The following is a description of a gene set: Genes down-regulated in skin from 129S1 mice after injection of: control versus Trypanosoma cruzi (strain Y). from publication Chessler AD, Unnikrishnan M, Bei AK, Daily JP, Burleigh BA (PMID 19201883) species: Homo sapiens Human Gene Set: GSE13522_CTRL_VS_T_CRUZI_Y_STRAIN_INF_SKIN_129_MOUSE_DN To investigate the early host response triggered by three different strains of Trypanosoma cruzi at a local infection site, changes in host gene expression were monitored in a murine intradermal infection model using Affymetrix oligonucleotide arrays. Robust induction of IFN-stimulated genes (ISGs) was observed in excised skin 24 hours post-infection where the level of ISG induction was parasite strain-dependent with the least virulent strain triggering a muted IFN response. Infection of mice immunodepleted of IFNγ-producing cells or infection of IFNγ-deficient mice had minimal impact on the IFN response generated in T. cruzi infected mice. In contrast, infection of mice lacking the type I IFN receptor demonstrated that type I IFNs are largely responsible for the IFN response generated at the site of infection. These data highlight type I IFNs as important components of the innate immune response to T. cruzi the site of inoculation and their role in shaping the early transcriptional response to this pathogen. We used microarrays to detail the local host transcriptional response to intradermal T. cruzi infection in WT mice and mice depleted of NK cells, or deficient in IFN-gamma or type I IFN responses. Additionally we compared the local host-transcriptional response generated to infection with 3 different strains of Trypanosoma cruzi (Y, Brazil, and G)., and this is the list of marker genes: SHC4, POPDC2, ADGRD1, ADORA2A, LAPTM4B, RHBDL2, PIR, TAB2, LPAR4, SMOX, ARMCX6, PRSS46P, ABCA2, PHLPP1, RSRP1, TCF7L1, MYORG, NOL3, GPR143, HOMER2, FAM53B, TCF25, SAV1, CDC42SE2, TAS1R1, ENO3 (enolase 3), MAT2B, COL4A4, SNX33, DNAH7, CCDC160, CAVIN1, RBPMS2, PRPH2, SPHK2, ZNF585A, PATL2, RELB, SFXN3, COL19A1, CUBN, MRTFB, LAD1, TMEM222, STAG1, PTDSS1, PRDM2, PRKX, SELENOM, PFN2, RPL5, MTMR3, BRINP1, ZBED3, PTPN5, ZNF354A, STON1, FHL1, ADAMTS6, CAMK2N1, OCRL, MFSD2B, MEX3B, PHF23, F7, CTDSP2, CCDC162P, C8orf74, OLIG1, STAM2, RRAGD, B3GNT5, GMCL1, RXRA, NECAP2, ZNF521, MAGED1, MTMR11, PRKAG2, KDM8, BARHL2, CAST, NAP1L3, CYP3A7, BIN1, KCNJ9, C5orf52, SOX30, FCHSD2, ANKRD2, NLRP4, KCNA5, EDEM2, STAT5B, CCDC92, CLVS1, SPAG4, AHCYL2, FBXO45, ARHGEF11, ID3, CRKL, CD5, PLCL1, BRF2, SNX18, SLC37A2, ASCL1, S100G, CCDC116, FAM98C, SUSD2, ID4, PCMTD1, PFAS, GPRASP2, CYBRD1, NHLH2, ESYT2, BIRC2, TOM1L2, ATP1B3 (NCBI Gene Id 483), ARHGEF16, G6PC2, PROX1, FNDC9, RASSF9, TNP1, LYSMD2, ATP10D, TPPP3, RPRML, KIF5C, SWAP70, RECK, PDGFA, ZFP64, CERS4, RIPPLY3, SLC12A6, NUDCD3, PELI2, SRRM1, SETX, FLOT1, CD81, PCTP, SLC25A31, NME8, FBXO31 (NCBI Gene Id 84204), CATSPERD, TRIM40, BCL2L1, KCTD20, SELL, IGF1R, MACROH2A2, WNT3, PITPNB, KIF9 (NCBI Gene Id 64147), ITGA7, DSPP (NCBI Gene Id 7888), CERK, LRRC8C, SKIL, SCN11A, RALGDS, PTPN13, ARMCX4 (armadillo repeat containing X-linked 4), PDZD9, TRIM62 (tripartite motif containing 62), CREBL2, ITGB6, SLAMF9, CCT6B, KLF9, SUPT7L, HNRNPC, GLIS3, TRDN, RFXANK, PTF1A, DDX41, IGSF3, PEAK1, DDX47, SLC52A3, ZFP69, PRNP, ANKRD29, TMTC2, FAM118B, CRH, VASN, YPEL3 (NCBI Gene Id 83719), CYP4V2, IGF2R, NFIB, HSF4, UGT3A2